Given this list of marker genes AVP, ANKRD9, TRPC3 (NCBI Gene Id 7222), TMCO1, RNASEK, FATE1, NPPB, ZNHIT1, MYH7B, CALB1, PLN, GP5, KEL, TBXAS1, ATP6V1H, SLC8B1, WNT5A, NPTN, SLC45A2, PRKD1 (NCBI Gene Id 5587), ATP12A, STK39, KL, CCL15, ITPR3, ITPR2, SLC10A7, CALCA, TM9SF4 (NCBI Gene Id 9777), BOLA2B, HEXB, SLC31A1, RHCG, CCL13, CCL1, KCNQ1, CHERP, FAM3A, P2RX7, CASR, SLC30A10, XCL1, HEPHL1, PTK2B, AP3B1, ATP2B2, STC2, FECH, FRRS1, NPY (NCBI Gene Id 4852), APLNR, PSEN2, ATP2B4, F2RL3, BDKRB1, SLC12A5, BOK, EXT2, SLC30A9, SLC25A23, CYP11B2, SLC26A4, KCNJ2, SLC30A2, LCK, CALM2, ATP6V0E1, GRINA, ISCU (iron-sulfur cluster assembly enzyme), MC3R, P2RY6, CXCL10, CCDC22, ASPH (NCBI Gene Id 56921), SMAD5, AVPR1A, RHAG, ANKH, CDH5, SLC4A9, MIR1-1, MYC (NCBI Gene Id 731404), ATP2A2, APP, NTSR1, CCL5, COX19, SLC22A17, CAV1, CACNA1C (NCBI Gene Id 775), CASQ2, CXCL11 (NCBI Gene Id 6373), IFNG, HCRTR2, FTL, TRPC1, ATP5F1B, HFE, PPT1, VAPB, GDF2, RAB20, CCL21, FTHL17, KCNE3, HERPUD1, NCOA4, TMTC4, DRD2, HYAL2, HCRTR1, NT5E, TMC6, SLAMF8, CCL8, TFR2, KCNA1, SLC8A3, UMOD, SLC24A5 (solute carrier family 24 member 5), EDN3, MT1B, WFS1, GP1BB (NCBI Gene Id 89199), CCR5, SLC9A4, MT1H, CYP4F2, SLC1A3, PRKACA, TMEM199, CORO1A, TNFSF11, DIAPH1, ERC2, GLRX3, HVCN1, DRD3 (dopamine receptor D3), KCNJ10, CYBRD1, PML, OCA2, MAIP1, SNCA, CTRC, COMT, TMTC2, PLCB4, LIME1, BOLA2, ATP2B1 (ATPase plasma membrane Ca2+ transporting 1), MICU1, TMEM64, AGT, SLC9A5, ERFE, MT4, DRD5, SLC4A7, DRD4, CPS1, MIR93, ELANE, WNK4, LAMP2, SNAPIN, ADCY8, FAM20A, HTR2B, HEPH, THY1, CYP4F12, CACNA1S, NPSR1, MT2A, SLC9A7, CA12, TCIRG1, KCTD7, MIR210, HTR2C, SLC39A4, STIM2, ATP6V0A1, CFTR, TMEM94, ATP6V0D1, CCL19, SLC9A3, ACVR2B, CCR2, TGFB1, CYB561A3, GRM5, CNNM3, NDFIP1, CCL23, PSEN1, ATP6V0A4, TMEM38B, NAGLU, EDN2, TGM2, ROGDI, METTL21C, SLC41A1, CAPN3, HTT, IL1A, MCUB, C19orf12, SLC39A5, UPK3A, CYBA, XCR1, SLC12A7, ATP6V1B2 (ATPase H+ transporting V1 subunit B2), SLC9C1 (solute carrier family 9 member C1), CNNM4, HPX, TRPV5, MT1F, KCNH2, SLC12A8, ATP2B3, SYPL2, MT1DP, PRKCB, ATP2A1, TRPA1, CLIC2, CIB2, CA7, SCNN1G (NCBI Gene Id 6340), ATP6V0B, SLC9B1, PTH1R, TFRC, SLC12A2, ATP2C2, STC1, AGTR1, SCO2, SELENOK, EPAS1, CAV2, HJV, ATP1A1, TMEM203, VDR, ADORA1, CCDC115, CLN5, PDZD8, ATP13A4, CEMIP, PLCE1, CD19, ACO1, WNK2, MT1G, SLC46A1, TMEM175, ATP2A3, KCNMA1, ATP1A2, CCL11 (NCBI Gene Id 6356), UNC80, EXT1, CALB2, HTR2A, DMTN, CA2, SOD1, SLC30A7, ATP2C1 (ATPase secretory pathway Ca2+ transporting 1), CUTC, LACRT (lacritin), ATP1B1, TMPRSS6, CXCL12, SLC8A1, FTH1P19, SLC30A5 (solute carrier family 30 member 5), SLC12A4, ATP4B, SLC30A1, P2RX1, MAPK3, ANK2, RAB39A, CP, PACS2, JPH4, BCL2, TASL (TLR adaptor interacting with endolysosomal SLC15A4), FTH1, RAP1GDS1, BAX, TMEM9, EIF2AK1 (eukaryotic translation initiation factor 2 alpha kinase 1), SCNN1D, CYP4A11, CX3CL1, XK, FGF23, CLIC4, IREB2, P2RY1, CCKBR, DISC1, DMXL1 (NCBI Gene Id 1657), XIAP, ATP4A, ATP6V1B1, TMEM106B, SPX, TRPC5, CLN6, AKAP6, TRIM24, SLC4A11, CREG1, CCR1, RAB7A, LAMP1, ABCC6, SLC9A9, ATG5, SLC8A2, VPS54, MT1M, SV2B, LCN2 (NCBI Gene Id 3934), HMOX1, TMBIM6, RAB38, CHD7, COX10, SCARA5, ALPL, AQP11, B2M, PIK3CB, HRC, EPB42, TRPV6, STOML2, CSRP3, SLC39A12, ERO1A, CYB561, RYR3, SLC24A4, SMAD9, FGF2, CHRNA7, SGCD, GP1BA (NCBI Gene Id 2811), CNGB1, SLC9A2, MICU2, ATP6V1D, STEAP4, RYR2, CNNM2, CCL7, SLC11A2, CCL3, PRNP, CLDN16, ATF4, CALM3, ATP6V0D2, WBP2NL, TMC8, SLC35G1, STEAP2, PDE4D, PRKCE, CAV3, GP9, CORIN, ITGB3, MT1X, FGFR1, FKBP1A, TNNI3, EGLN1, S100A14, SLC30A8, CALM1, JPH2, PTPN6, TRPM8, SLC9A6, TMEM165, PDK4, DMD, ATP1A4, SLC12A3, CALCB (calcitonin related polypeptide beta), SNX10, TMEM38A, FZD9, SLC24A2, ABCB7, PLCL2, SLC39A10, SMAD4, SLC39A13, VPS33A, HSP90B1, UBE3A, GSTM2, DHRS7C, BAK1 (BCL2 antagonist/killer 1), TPCN2, LETMD1, LACC1, FBXL5, COMMD1, PRND, LYN, ATP7A, JPH3, CAMK2D, SLC4A4, GPR89B, IL13, MT1A, SPPL2C, SLC9A8, MICU3, SLC12A6, NPR1, WNK3, TUNAR, SLC1A1, SLC4A2, HAP1, CLN3, MCU, CXCL9, ITPR1, SLC4A5, CNNM1, KCNA5, ATP6V0C, SLC4A3, NOL3, CDH23, PLCB1 (NCBI Gene Id 23236), PDK2, CRH, TSPOAP1 (NCBI Gene Id 9256), HAMP, IBTK, BOLA1, GLRX5, RGN, BTBD9, YWHAE, SLC24A3, SLC26A3, BNIP3, AFG3L2, EDNRA, CACNB4, CACNB2, GRIK2, SPNS1, GRM1, DMPK, MT1HL1, SLC39A9, SOD2, LRRK2, TPT1, F2, LCN6, MAPK1, PDPK1, WNK1, NGF, UBASH3B, ATP6AP1, SCN7A, FTMT, EDN1, CHP1, P2RY2, CCR7, SLC39A14, ATP6V1A, RMDN3, ATP13A1, ALAS2, ATP13A5, CD40, ATP6V1G1, PLCG2, SLC25A27, MECR, ATP13A3, MCOLN1, CLCC1, COX11, PKHD1, DRD1, ATP1A3, DDIT3, PTH, TRPC6, MCUR1, GPER1, LETM1, TRPC4 (transient receptor potential cation channel subfamily C member 4), GPR89A, BMP6, SCO1, SLC39A6, GRIN1, SLC4A1, MT1E, SLC9C2, EDNRB, KLHL3, SLC9A1, ATP1B2, SRI, PLCB3, TRPM7, CISD1, SCNN1B, ATOX1, TRPC7, CCL14, RYR1, SLC9B2, THADA, ATP7B, ATP1B3, MINPP1, GHITM, GSTO1, SLC4A8, NUBP1, BOLA3, MIR133A1, ARF1, PLCH1, ABL1, SMDT1, CYP27B1, DBNDD2, ATP13A2, SLC12A1, CLCN3, MTLN, TMPRSS3, SELENON, SMAD1, PLCL1, APOE, SV2A, TRPM2, CIB3, FKBP1B, SLC31A2 (solute carrier family 31 member 2), CASQ1, ATP6V0A2, CCDC47, CNR1, NPPC, SLC40A1, CXCR3, PTPRC, MT3, TMEM178A, GRN, ANK3, TRPV4, SLC24A1, FLVCR1, NEO1, TTC7A, KDR, ATP6AP2, GRID2IP, ABCB6, HIF1A, IMMT, SLC26A6, JPH1, ANXA6 (annexin A6), PLCB2, PLCH2 (phospholipase C eta 2), ATP6V1F, PKD2, SLC11A1, TESMIN (NCBI Gene Id 9633), FXYD2, FLNA, GCM2, SLC39A8, DMXL2, ATP6V0E2, PICALM, SLC12A9, FXN, F2R, GPR12, SLC39A7, CALR, FASLG, KCNK16, KCTD17, TF, PLCG1, STIM1, TRDN, OSBPL2, OTC, SCNN1A, MLLT6, SLC4A10, here is a description of the gene set: Any process involved in the maintenance of an internal steady state of monoatomic ions within an organism or cell. Monatomic ions (also called simple ions) are ions consisting of exactly one atom. Human Gene Set: GOBP_MONOATOMIC_ION_HOMEOSTASIS species: Homo sapiens